Given this list of marker genes PSMA2, MSS51, FANCB, AIP, HCFC2, USP40, GXYLT1, GPANK1, NARS2, RAC3, SPACA9, CIBAR1, DDX6, CKLF, TUBE1, KDM1B, ESCO2 (establishment of sister chromatid cohesion N-acetyltransferase 2), PPIP5K1, PRRC1, GLRX3, UNG, HECTD3, YTHDF3, AGFG2, MED1, APOBEC1, GPR19, MAN2A1, VEGFC, CAMSAP2, SIK2, GPR84, PPP2R5E, TRIM36 (tripartite motif containing 36), GK, ITGB7, MMP8, TNIK, PROM1, PRPF40A, PKD2L2, CRY1, CNGA2, ZNF397, DBI, DUBR, PRSS16, TUSC3, LRRC24, MLX (MAX dimerization protein MLX), TREML4, MDC1, IL3RA, PIGF, HERPUD2, KRTAP2-4, COG7, ARL6IP6, INO80D, RTTN, TREX1, ZNF367, TMEM223, FADD, NELFCD, CD99, SOCS7, SH3BP2, HIPK2, DDX31, RAB29, PPP1R7, C15orf40, SLC26A6, FBLN2, UTP23, ENO1, SYNJ1, STAG1 (STAG1 cohesin complex component), SLC22A15, OTULIN, MTIF3, SCFD2, NDUFA7, CX3CR1, GOSR1, UXS1, APTX, OSBPL11, ERRFI1, NMB, L1CAM, GPR132, DTX2, PLAA, SASH3, SETD4, CAMK2N1 (NCBI Gene Id 55450), PRKACA, UQCR10, NUP133, LUZP1, DLEU7, MRPS26 (mitochondrial ribosomal protein S26), GSK3B, KCTD20, DDX46, MED6, UBE2G2, SLC11A1 (solute carrier family 11 member 1), THOC7, METTL17, DENND2B, CDK11B, PGD, APOBR, LIN9, LIG4, UBE2T, TOMM70, NCSTN, ZNF341, DDX55, PIGB, CLEC4A, F13B, RRP7A, SPRYD3, GATA5, TBC1D10B, DDI2, PRKDC, TSHZ3, STMP1, RABGAP1L, UCP2, ARK2C, GSKIP, JADE2, CYB561A3, C2, TSGA10, PDZD4, EPC2, ANKMY2, SUSD6, CDK5RAP2, IFIT1, RHOG, AGBL4, TPGS1, MDM1, ABHD1, ADAR, LEF1, NBAS, POGZ, NDUFA6, RBKS, TBC1D12, MDH2, FEN1 (flap structure-specific endonuclease 1), STYK1, ATXN10, MOB1B, NFATC2, ZNF251, MKNK2, WSB2, NME2, GRAMD2B, TOR2A, ATOSA, RNPC3, DCTN5, TRAF3, TUBGCP3, DDIAS, ING3, OGFOD2, TPM3, CLN5, FBRSL1, KIN (Kin17 DNA and RNA binding protein), CLEC2L, USP39, FAM204A, ITLN1, MED11, RPL13, EDC4, FHIP2A, BECN1, KCNQ5, ASTE1, POLR3F, PPP1R12C, SREBF1, SEC22C, TMTC1, here is a description of the gene set: from publication Mages J, Dietrich H, Lang R (PMID 18086374) Among the multiple mechanisms that control the intensity and duration of macrophage activation, the development of a state of refractoriness to a second stimulation in cells treated with LPS has long been recognized. Release of inhibitory cytokines and alterations in intracellular signaling pathways may be involved in the development of LPS tolerance. Although a number of molecules have been implicated, a detailed picture of the molecular changes in LPS tolerance is still missing. We have used a genome-wide gene expression analysis approach to (i) define which fraction of LPS target genes are subject to tolerance induction and (ii) identify genes that are expressed at high levels in tolerant macrophages. Our data show that in LPS tolerant macrophages the vast majority of LPS-induced gene expression is abrogated. The extent of tolerance induction varies for individual genes, and a small subset appears to be excepted. Compared to other negative control mechanisms of macrophages, e.g. IL-10-induced deactivation, LPS-tolerance inhibits a much wider range of transcriptional targets. Some previously described negative regulators of TLR-signaling (e.g. IRAK-M) were confirmed as expressed at higher levels in LPS-tolerant macrophages. In addition, we discuss other potential players in LPS tolerance identified in this group of genes. Genes down-regulated in untreated macrophages: naïve versus tolerant. Human Gene Set: GSE8621_UNSTIM_VS_LPS_PRIMED_UNSTIM_MACROPHAGE_DN species: Homo sapiens